The following is a description of a gene set: species: Homo sapiens Gait imbalance Human Gene Set: HP_GAIT_IMBALANCE, and this is the list of marker genes: ERLIN2, GTF2IRD2, MPV17, MLXIPL, SETX, FBXO7, BAZ1B, OCA2, PTEN, HTT (NCBI Gene Id 3064), PARK7, CHD4, SNCA, FLNC, SPTLC1, TMEM270, GTF2IRD1, PRKN (NCBI Gene Id 8004), CAPN1, FKBP6, CCDC28B, RFC2, ATP5F1D, SYNJ1, ATXN1, GTF2I, SPTLC2, ARL6, LRRK2, BBS1, PUS3, ELN (elastin), PODXL, PINK1, BUD23, FXN, TELO2, GALT, METTL27, DNAJC30, GDAP2, PMP22, SPEN, LIMK1, TTBK2, ATXN10, MAPT, ATL1, RNASEH1, ADGRG1, NCF1, SLC2A3, PIGG, HTRA2, KAT6A, SLC52A3, ATL3, HK1, DEAF1, TAF1, VPS13C, DNAJC6, ALS2, PIK3R5, CLIP2, TBL2, UCHL1, BCAS3, UBE3A, NDUFA1, VPS37D, EIF4H, STX1A, VCP, RRM2B